The following is a description of a gene set: Genes having at least one occurrence of the motif GKSRKKCAGMCANCY in the regions spanning 4 kb centered on their transcription starting sites. This matches the SMAD4 transcription factor binding site V$SMAD4_Q6 (v7.4 TRANSFAC). studied in species Homo sapiens Human Gene Set: SMAD4_Q6, and this is the list of marker genes: DHX40, CLOCK, TCF4, PDGFRA, FKBP10, NAB2, PSMC5, USP2, POU2AF1, HNRNPK, NFKB2, AVP, ACY3, AP2M1, MYL6B, TSEN54, SP8, TNFRSF12A, CMTM4, CACNG3, RPS6KA3, VDR, RASAL2, CDK15, DACH2, KAZN, TRIM8, FGF4, LAMC2, SPCS1, DCTN1 (NCBI Gene Id 82109), APBB1, PRKAG1, TOMM40L, SLC25A35, HSALR1, HOXA9, SRSF6 (NCBI Gene Id 6431), EVX1, ACTL6B, ARHGEF19, PURA, CDH13 (NCBI Gene Id 1012), SIAH3, NUDCD1, BNC2, NTF4, KMT2E, TREML2, RHOQ, CATIP, CADM1, CHRM1 (cholinergic receptor muscarinic 1), MMP11, SUV39H2, PFN2, PLA2G2F, PARP8, ZNF282, AGBL5, RCAN1, NR2F1 (nuclear receptor subfamily 2 group F member 1), DUSP5, SCYL3, ZNRF2, PCBP4, VGF, PLEC, HYAL2 (hyaluronidase 2), PARP16, TBCB, EIF4A1, PPP3CA, EPHA2, IRS1, EPC1, ETV4, WNT1, KCTD15, LDB1, FASTK, MAFB, HEPACAM, LOXL3, RUNDC3A, NR1D1, TXNDC12, FMO2 (NCBI Gene Id 2327), HOXA6, HMGN5, MRI1, COL25A1, ARID1A, BAHD1, CGB7, GDF1, MIR22HG (NCBI Gene Id 84981), ATP6V1E2, RORA, SDR9C7, OTX2, SSBP3 (NCBI Gene Id 55126), DOK1, PPP2R2B, ADAMTS4, SULF1, SNX12, ZMYND8, TBX5, LGI1, KCNN2, KIRREL3, PIEZO1, LMO1, ACACA, CRK, MROH2B (NCBI Gene Id 133558), RALA, APH1A, CA9, RPS8, AGAP2, PRR35, RGS3, CXADR, FOXB1, YPEL1, DHRS3, NTRK3, POU4F3, TBX6, WNT3, PHF8, PLCXD2, STX5, GNB2, PBX3, FAM83F, MACROD2, LHX4, ANKS1B, WDR13, HNRNPUL1, NAPEPLD, RMI1 (NCBI Gene Id 80010), NOTCH3, POLR2I, LHB, DIABLO (diablo IAP-binding mitochondrial protein), ABCA1, ZNF800, TET2, TMCC1, CACNA1G, PAX1 (NCBI Gene Id 5075), ZNF710, FGF16, PRRC2C, TMEM69, FLRT1, CREB1, ERO1B, THRA, AKAP4, COL1A2, PRKCZ, MYLK, TNS2, POLD4, SRRM4, WASF2, NIBAN1, MEIS2, TMEM25, CLVS1, PPP3CB, ZNF410, SLC25A14, VAPA, UBE4B, ADAMTSL1, ZNF296, CASKIN2, ELOVL5, SYVN1, HOXA3, IL23A, SLC12A5, CALD1, LINC00474, LINC01138, MAF, TRIM3, SST, SLC22A17, LMO4, MCRS1 (NCBI Gene Id 10445), NXPH3, DLGAP4, CBFA2T3, GOLGA2P5, FLI1, PICK1, CLC, LARP4, EPHB1, RTN3, TMEM109, EEF1A1, KLF7, PDP1, CDK6, AMMECR1, CALM1, RAB1B, TRPS1, MEF2C, FOXI1, PAK3, PHF12, AGER, P3H4, WDR81, TRAF3, CERS1, ATXN7L2, HOXB1, ADORA2B, SIPA1, C11orf87, MGAT4C, ATP2A2, KCNH6, HHEX, FBRS, HOXA10, VEZF1, HYCC1, GBA2, LINC01106, MTCL2, NFATC4, PTBP2, IL17RC, UBE2E1